Given this list of marker genes NFYC, DCP2, EXOSC1, ATF3, IGFBP1, EXOSC6 (NCBI Gene Id 118460), ASNS, HERPUD1 (homocysteine inducible ER protein with ubiquitin like domain 1), DIS3, NFYA, KHSRP, EXOSC9, CXCL8, NFYB, ATF4, EXOSC3, EXOSC4, EXOSC8, PARN, CCL2, CEBPB, EXOSC5, ATF6, EXOSC7, CEBPG, EXOSC2, DDIT3 (DNA damage inducible transcript 3), here is a description of the gene set: Human Gene Set: REACTOME_ATF4_ACTIVATES_GENES_IN_RESPONSE_TO_ENDOPLASMIC_RETICULUM_STRESS species: Homo sapiens ATF4 activates genes in response to endoplasmic reticulum stress